The following is a description of a gene set: The process in which the renal system vasculature is generated and organized. Morphogenesis pertains to the creation of form. Human Gene Set: GOBP_RENAL_SYSTEM_VASCULATURE_MORPHOGENESIS studied in species Homo sapiens, and this is the list of marker genes: PDGFRA, PKD2, NOTCH2, BMP4, NRP1, NOTCH3, TCF21, PDGFRB